Given this list of marker genes Agxt, Shmt2, Phgdh, Psph, Sdsl, Psat1, Sds, Shmt1, Ndp, Srr, Cbs, here is a description of the gene set: studied in species Mus musculus The chemical reactions and pathways involving L-serine, the L-enantiomer of serine, i.e. (2S)-2-amino-3-hydroxypropanoic acid. Mouse Gene Set: GOBP_L_SERINE_METABOLIC_PROCESS